Given this list of marker genes Ap2b1, Ctbp1, Ap2s1, Dnajc6, Ap2m1, Picalm (phosphatidylinositol binding clathrin assembly protein), Snap91, here is a description of the gene set: studied in species Mus musculus Mouse Gene Set: GOCC_EXTRINSIC_COMPONENT_OF_PRESYNAPTIC_ENDOCYTIC_ZONE_MEMBRANE The component of the presynaptic endocytic zone membrane consisting of gene products and protein complexes that are loosely bound to one of its surfaces, but not integrated into the hydrophobic region.